The following is a description of a gene set: studied in species Homo sapiens Human Gene Set: HP_ABNORMAL_1ST_METACARPAL_MORPHOLOGY Abnormal 1st metacarpal morphology A structural anomaly of the first metacarpal., and this is the list of marker genes: PQBP1, TBX5, SETBP1, TAF6, SMC3, NONO, SOX9, FZD2, DLK1, SRCAP, VAC14, IHH, FANCD2, SMC1A, SF3B4, GNAS, PCNT, HDAC8, LAMA5, BMPR1B, NOG, NPR3, MEG3 (maternally expressed 3), CANT1, TRIO, FIG4, BRD4, LMBR1, GDF5, XRCC2, RNU4ATAC, FANCI, SHH, ROBO1, VPS35L, ACVR1, HOXA13, RTL1, NIPBL, SALL4, RAD21